The following is a description of a gene set: species: Mus musculus Any process that stops, prevents or reduces the frequency, rate or extent of vascular associated smooth muscle cell apoptotic process. Mouse Gene Set: GOBP_NEGATIVE_REGULATION_OF_VASCULAR_ASSOCIATED_SMOOTH_MUSCLE_CELL_APOPTOTIC_PROCESS, and this is the list of marker genes: Gapdh, Igf1, Slc7a5, Gapdhrt (glyceraldehyde-3-phosphate dehydrogenase, retrotransposed), Cftr, Gapdhrt2, Dnmt1